Given this list of marker genes Anxa11, Kcnmb2 (NCBI Gene Id 73119), Abcc9, Plcg2, Kcnq2, Cpne2, Kcnq3 (potassium voltage-gated channel, subfamily Q, member 3), Slc25a24, Wnt5a, Pcdh15, Rasa4, Adcy8, Penk, Pla2g4a, Akap5, Fosb, Endog, Micu1, Braf, Calm1, Rasgrp2, Gpld1, Cacng2, Neurod2, Crp, Lce1d, Trpm2, Dpep1, Krt10, Iqgap1, Gdi1, Trpc3, Mnat1, Pkd2, Nrxn1, Ncstn, Cpne8, Sucnr1, Htt, Nfatc1, Ppp3ca, Calm3, Prkaa1, Micu2, Guca1a, Asph, Kcnmb1, Pdcd6, Ppif, Wnk1, App, Anxa7, Capn3, Mef2c, Acer1, Fga, Syt3, Cpne4, Inhbb, Cav1, Junb, Trpv6, Nfatc3, P2rx7, Tuba1a (NCBI Gene Id 22142), Plcd1, Ryr3, Sec31a, Mef2a, Kcnb1, Mylk, mt-Cytb, Pef1, Prkaa2, Ptk2b, Aanat, Grxcr1, Edn1, Ttn, Nlgn1 (NCBI Gene Id 99949, neuroligin 1), Sdc1 (NCBI Gene Id 20969), Adam9, Smpd1, Cpne3, Hnrnpd, Hpca, Cpne9, Jund, Pde1c, Nfatc2, Adgrv1, Akr1c18, Ryr2, Anxa5, Slc25a12, Trpc1, Ryr1, Cpne1, Kcnma1, Fgg, Mcoln1, Homer1, Fgb, Jun (NCBI Gene Id 16476), Entpd6 (ectonucleoside triphosphate diphosphohydrolase 6), Add1, Vps54, S100a16, Lcn6, Tnnt2, Fus, Pcsk1, Alox15, Kcnmb3 (potassium large conductance calcium-activated channel, subfamily M, beta member 3), Micu3, Ahcyl1, Chp2, Adcy1, Egfr, Mttp, Hcn1, Cpne7, Casr, Itpr3, Slc25a23, Calm2, Fos, Stim1, Apobec1, Itpkb, Cpne5, Itpkc, Crhbp, Ect2, Cpne6, Slc25a13, Alox5ap, Carf, Itpka, D2hgdh, Kcnh1, P2rx5, Kcnmb4, Thbs1, Clic4, Syt1, Gipr, Txnip, Ep300, Lgmn, Scn5a, Rasal1 (RAS protein activator like 1 (GAP1 like)), Eef2k, here is a description of the gene set: Mouse Gene Set: GOBP_RESPONSE_TO_CALCIUM_ION studied in species Mus musculus Any process that results in a change in state or activity of a cell or an organism (in terms of movement, secretion, enzyme production, gene expression, etc.) as a result of a calcium ion stimulus.